Given this list of marker genes MMP1, NFKB1, EGR1, STAT5A, CDK5R1, HDAC1, MAPK10, GATA3, IFNG, EP300, RELA, PBX1, CDKN1A, MAPK11, CREBBP, KRT5, GSK3B, IL6, HDAC2, STAT5B, SFN, TP53, MAPK14 (mitogen-activated protein kinase 14), MAPK3, SUMO2, FGG, MAPK1, SELE, KMT5B, NR4A1, POU1F1, CGA, VIPR1, PRL, IL13, KRT14, CSN2, ICAM1, POU2F1, NCOA2 (NCBI Gene Id 10499), CDK5, NCOA1, CREB1, BGLAP, MDM2, YWHAH, FKBP4, SMARCC1, NR3C1, AKT1, SMARCD1, KRT17, SGK1, NR1I3, STAT1, IL4, HSP90AA1, MAPK9, PRKACB, NFATC1, CXCL8, IL5, JUN, AFP, SMARCA4, TBX21, FOS, SMARCC2, SPI1, PRKACA, TBP, PCK2, PPP5C, FKBP5, IRF1, IL2, MAPK8, BAX, CSF2, TSG101, PRKACG, POMC, here is a description of the gene set: Glucocorticoid receptor regulatory network from publication Schaefer CF, Anthony K, Krupa S, Buchoff J, Day M, Hannay T, Buetow KH (PMID 18832364) studied in species Homo sapiens Human Gene Set: PID_REG_GR_PATHWAY